The following is a description of a gene set: c-Ski is an important corepressor of transforming growth factor-beta (TGF-beta) signaling through its ability to bind to and repress the activity of the Smad proteins. It was initially identified as an oncogene that promotes anchorage-independent growth of chicken and quail embryo fibroblasts when overexpressed. Although increased Ski expression is detected in many human cancer cells, the roles of Ski in mammalian carcinogenesis have yet to be defined. Here, we report that reducing Ski expression in breast and lung cancer cells does not affect tumor growth but enhances tumor metastasis in vivo. Thus, in these cells, Ski plays an antitumorigenic role. We also showed that TGF-beta, a cytokine that is often highly expressed in metastatic tumors, induces Ski degradation through the ubiquitin-dependent proteasome in malignant human cancer cells. On TGF-beta treatment, the E3 ubiquitin ligase Arkadia mediates degradation of Ski in a Smad-dependent manner. Although Arkadia interacts with Ski in the absence of TGF-beta, binding of phosphorylated Smad2 or Smad3 to Ski is required to induce efficient degradation of Ski by Arkadia. Our results suggest that the ability of TGF-beta to induce degradation of Ski could be an additional mechanism contributing to its protumorigenic activity. studied in species Homo sapiens Selected genes implicated in metastasis and epithelial-to-mesenchymal transition (EMT) which were down-regulated in MDA-MB-231 cells (breast cancer) upon knockdown of SKI by RNAi. Human Gene Set: LE_SKI_TARGETS_DN from publication Le Scolan E, Zhu Q, Wang L, Bandyopadhyay A, Javelaud D, Mauviel A, Sun L, Luo K (PMID 18451154), and this is the list of marker genes: EFEMP1, DLX4, COL18A1, TFPI2, ID4, FHL1, SOCS2